The following is a description of a gene set: Expressive language delay studied in species Homo sapiens A delay in the acquisition of the ability to use language to communicate needs, wishes, or thoughts. Human Gene Set: HP_EXPRESSIVE_LANGUAGE_DELAY, and this is the list of marker genes: RSPRY1, ZEB2, SDHA, GRIA3 (glutamate ionotropic receptor AMPA type subunit 3), TUBB3, YME1L1, TAF4, SDHB, TAF1, GNE, KMT2D, SHH, FOXP2, ARID1B, POGZ, RAI1, SHMT2, SDHD, EHMT1, SDHAF1, KMT2C, TGIF1, CRIPTO, STIL, RAP1GDS1 (Rap1 GTPase-GDP dissociation stimulator 1), FLCN, SIX3, SH2B1, SCN4A, FGF8, YARS1, PTCH1, TNNT1, ASXL1, SLC25A36, STAG2, WARS2, MED23, GLI2, DISP1, DPYD, ZIC2, AFG2A, GNB1, FOXH1, GAS1, AHDC1, CDON, NODAL, GNPTAB, FOXP1, NSD1, PUF60, SRCAP, DLL1, HERC1